The following is a description of a gene set: Reactome Pathway: Synthesis of PA electronically inferred by orthology from the curated human pathway This event has been computationally inferred from an event that has been demonstrated in another species.<p>The inference is based on the homology mapping from PANTHER. Briefly, reactions for which all involved PhysicalEntities (in input, output and catalyst) have a mapped orthologue/paralogue (for complexes at least 75% of components must have a mapping) are inferred to the other species. part of: Glycerophospholipid biosynthesis studied in species Mus musculus, and this is the list of marker genes: Pla2g2a, Pla2g5, Pld2, Pla2g2e, Pla2g1b, Pla2g2d, Agpat4, Lclat1, Pld6, Agpat1, Pla2r1, Gpd1, Ddhd2, Alpi, Pla2g12a, Pla2g2f, Lipi, Agpat3, Lpcat4, Gpat2, Gpam, Pla2g4d